Given this list of marker genes NR1H3, CCND1 (NCBI Gene Id 893), CDK4, RXRA, PSME3, MYC, here is a description of the gene set: studied in species Homo sapiens Pathway Definition from KEGG: (Core+PSME3) -> (RXRA+NR1H3) => (CCND1,CDK4,MYC) HCV core to RXRA/LXRA-mediated transcription. Pathway ID: N00530. Pathway type: Pathogen. Pathway class: nt06263 Hepatocellular carcinoma. Human Gene Set: KEGG_MEDICUS_PATHOGEN_HCV_CORE_TO_RXRA_LXRA_MEDIATED_TRANSCRIPTION